Given this list of marker genes GGCX, F9, VKORC1, MGAT2, PMM2, SLC37A4, here is a description of the gene set: Decreased activity of coagulation factor IX. Factor IX, which itself is activated by factor Xa or factor VIIa to form factor IXa, activates factor X into factor Xa. Reduced factor IX activity studied in species Homo sapiens Human Gene Set: HP_REDUCED_FACTOR_IX_ACTIVITY